The following is a description of a gene set: species: Homo sapiens Human Gene Set: GOBP_DENDRITE_SELF_AVOIDANCE The process in which dendrites recognize and avoid contact with sister dendrites from the same cell., and this is the list of marker genes: DSCAML1, ROBO3, NEXN, CNTN2, TNN (NCBI Gene Id 63923), ROBO4, NPTN (neuroplastin), EMB, MYPN, BSG, CNTN6, CNTN4, IGSF9, PALLD, DSCAM, EXT1